Given this list of marker genes POR, CYP27A1, CYP2C9, ADH5, CYP21A2, CYP24A1, CYP8B1, CYP27B1, CYP4V2, AOC2, POMC, CYP2C8, MAOA, PAOX, CYP4F22, CYP39A1, ADH1C, CYP11B1, EPHX1, CYP7A1, AOC3, CYP2F1, CYP2A6, CYB5B, ACSS2, ARNT, FMO3, MTARC2, BPHL, PTGS1, CYP7B1, CYP51A1, AADAC, CES2, CYP3A4, SMOX, ADH4, CYP19A1 (NCBI Gene Id 1588), MAOB, CYP11B2, ALDH3A1, MTARC1 (NCBI Gene Id 64757), FMO1, NR1H4, CYP2A7, CYP4A22, FDXR, CYB5R3, CBR3, CYP1B1, ALDH1B1, CYP4F11 (cytochrome P450 family 4 subfamily F member 11), PTGIS, CYP4F3, CES1, CYP1A2, ALDH1A1, CYP46A1, CYP2C19, FDX2, CYP11A1, ALDH2, CYP2D6, AOC1, CYP4F8, CYP1A1, CMBL, CYP4B1, CYP2E1, ADH1A, CYP2B6, FDX1, PTGES3, AHR, CYP4F2, ACSS1, CYP2U1, TBXAS1, CYP26A1, CYP4A11, FMO2, CYP2S1, CYP2W1, ADH7, CYP26C1, CYP3A43, CES3, CYP2A13, CYP2C18, ADH6, NCOA1, AIP (NCBI Gene Id 9049), CYP3A5, CYP2J2, CYP4F12, CYP26B1, ADH1B, NCOA2, ARNT2, NQO2, HSP90AB1, CYP3A7, CYP2R1, RXRA, here is a description of the gene set: Phase I - Functionalization of compounds studied in species Homo sapiens Human Gene Set: REACTOME_PHASE_I_FUNCTIONALIZATION_OF_COMPOUNDS